The following is a description of a gene set: Mouse Gene Set: GOBP_CELL_DIFFERENTIATION_INVOLVED_IN_METANEPHROS_DEVELOPMENT studied in species Mus musculus The process in which relatively unspecialized cells acquire specialized structural and/or functional features that characterize the cells of the metanephros as it progresses from its formation to the mature state., and this is the list of marker genes: Cd34, Pax8 (NCBI Gene Id 18510), Cited1, Fat4, Tcf21, Sall1, Lif, Smo, Pax2, Wnt9b, Osr1, Nphs2, Stat1, Adipoq, Ctnnb1, Six2, Yap1, Pdgfb, Wnt4, Pou3f3, Lamb2, Grem1, Wwtr1, Gdnf